Given this list of marker genes H3C15, CDKN2A, MAPK1, UBE2S, CDK6, CDC16, NFKB1, RELA, RPS6KA1, CDKN2C, UBE2E1, H2AX, ANAPC7, CDKN1A, UBB, RPS6KA3, H2AC7, H2BC1, MAPK7, CDC27, H2BC14 (H2B clustered histone 14), H2AC6, VENTX, MAPK3, H2BC5, STAT3, FZR1, H3C1, H2BC17, CDC26, H2BC13, H2AC18, H2BC9, ANAPC15, CCNA1, CDKN2D, ANAPC4, UBE2C, JUN, EHMT1, CDK2, IL1A, H2BC4, RPS6KA2, CCNA2, H2BC3, CXCL8, H2AB1, ANAPC2, H2BC12L, CDKN2B, ANAPC11, CDC23, CEBPB, H2AJ, FOS, CDKN1B, EHMT2, ANAPC5, H2BC12, ANAPC16, RPS27A, ANAPC10, H2BC26 (NCBI Gene Id 128312), H2AC4, ANAPC1, IL6, UBA52, UBE2D1, H3-3A, H2BC11, H4C1, H2BC15, H2AC20, H2AC14, H2BC21, H2AZ2, IGFBP7, CDK4, UBC, here is a description of the gene set: species: Homo sapiens part of: Cellular Senescence The culture medium of senescent cells in enriched in secreted proteins when compared with the culture medium of quiescent i.e. presenescent cells and these secreted proteins constitute the so-called senescence-associated secretory phenotype (SASP), also known as the senescence messaging secretome (SMS). SASP components include inflammatory and immune-modulatory cytokines (e.g. IL6 and IL8), growth factors (e.g. IGFBPs), shed cell surface molecules (e.g. TNF receptors) and survival factors. While the SASP exhibits a wide ranging profile, it is not significantly affected by the type of senescence trigger (oncogenic signalling, oxidative stress or DNA damage) or the cell type (epithelial vs. mesenchymal). However, as both oxidative stress and oncogenic signaling induce DNA damage, the persistent DNA damage may be a deciding SASP initiator. SASP components function in an autocrine manner, reinforcing the senescent phenotype, and in the paracrine manner, where they may promote epithelial-to-mesenchymal transition (EMT) and malignancy in the nearby premalignant or malignant cells. Interleukin-1-alpha (IL1A), a minor SASP component whose transcription is stimulated by the AP-1 (FOS:JUN) complex, can cause paracrine senescence through IL1 and inflammasome signaling.<p>Here, transcriptional regulatory processes that mediate the SASP are annotated. DNA damage triggers ATM-mediated activation of TP53, resulting in the increased level of CDKN1A (p21). CDKN1A-mediated inhibition of CDK2 prevents phosphorylation and inactivation of the Cdh1:APC/C complex, allowing it to ubiquitinate and target for degradation EHMT1 and EHMT2 histone methyltransferases. As EHMT1 and EHMT2 methylate and silence the promoters of IL6 and IL8 genes, degradation of these methyltransferases relieves the inhibition of IL6 and IL8 transcription. In addition, oncogenic RAS signaling activates the CEBPB (C/EBP-beta) transcription factor, which binds promoters of IL6 and IL8 genes and stimulates their transcription. CEBPB also stimulates the transcription of CDKN2B (p15-INK4B), reinforcing the cell cycle arrest. CEBPB transcription factor has three isoforms, due to three alternative translation start sites. The CEBPB-1 isoform (C/EBP-beta-1) seems to be exclusively involved in growth arrest and senescence, while the CEBPB-2 (C/EBP-beta-2) isoform may promote cellular proliferation (Atwood and Sealy 2010 and 2011). IL6 signaling stimulates the transcription of CEBPB, creating a positive feedback loop. NF-kappa-B transcription factor is also activated in senescence through IL1 signaling. NF-kappa-B binds IL6 and IL8 promoters and cooperates with CEBPB transcription factor in the induction of IL6 and IL8 transcription. Besides IL6 and IL8, their receptors are also upregulated in senescence and IL6 and IL8 may be master regulators of the SASP.<p>IGFBP7 is also an SASP component that is upregulated in response to oncogenic RAS-RAF-MAPK signaling and oxidative stress, as its transcription is directly stimulated by the AP-1 (JUN:FOS) transcription factor. IGFBP7 negatively regulates RAS-RAF (BRAF)-MAPK signaling and is important for the establishment of senescence in melanocytes.<p>Please refer to Young and Narita 2009 for a recent review. Reactome Pathway: Senescence-Associated Secretory Phenotype (SASP)